The following is a description of a gene set: species: Mus musculus RHOD GTPase cycle Mouse Gene Set: REACTOME_RHOD_GTPASE_CYCLE, and this is the list of marker genes: Ankfy1, Diaph2, Actn1, Plxna1, Rbm39, Diaph3, Arhgap17, Mcam, Capzb, Stbd1, Lman1, Arhgap32, Vapb, Racgap1, Slc4a7, Arhgap39, Arhgap26, Steap3, Rhod, Add3, Cpne8, Akap12, Lmnb1 (NCBI Gene Id 16906), Pik3r2, Vrk2, Whamm, Tor1aip1, Pak5, Arhgap1, Vamp3, Plxnb1, Emd, Vangl1, Pgrmc2, Arhgap5, Esyt1, Efhd2, Mospd2, Lbr, Diaph1, Cav1, Pik3r1, Pak6 (p21 (RAC1) activated kinase 6), Arhgap21, Depdc1b, Arhgap12, Arhgap35, Rab7, Filip1, Golga2, Hint2